Given this list of marker genes STAT3, IL17RC, RNF31, PIK3CD, TGFB1, here is a description of the gene set: studied in species Homo sapiens Candida infections of the esophagus are considered opportunistic infections and are seen most commonly in immunosuppressed patients, the most common symptoms being dysphagia, odynophagia, and retrosternal pain. Candida esophagitis Human Gene Set: HP_CANDIDA_ESOPHAGITIS